The following is a description of a gene set: Genes up-regulated in the perivenous-type subclass of hepatocellular carcinomas. Sets created as part of a metaanalysis of nine public transcriptomic datasets merged into a metadataset including 1133 human hepatocellular carcinomas obtained after curative resection. For platform descriptions of each one of the 9 datasets, see Figure 1B in Désert et al., Hepatology (2017), 66: 1502-1518. species: Homo sapiens Hepatocellular carcinomas (HCCs) exhibit a diversity of molecular phenotypes, raising major challenges in clinical management. HCCs detected by surveillance programs at an early stage are candidates for potentially curative therapies (local ablation, resection or transplantation). In the long term, transplantation provides the lowest recurrence rates. Treatment allocation is based on tumor number, size, vascular invasion, performance status, functional liver reserve and on the prediction of early (< 2 years) recurrence, which reflects the intrinsic aggressiveness of the tumor. Well-differentiated, potentially low-aggressiveness tumors form the heterogeneous molecular class of non-proliferative HCCs, characterized by an approximate 50% beta-catenin (CTNNB1) mutation rate. To define the clinical, pathological, molecular features and the outcome of non-proliferative HCCs, we constructed an 1133-HCC transcriptomic metadata set and validated findings in a publically available 210-HCC RNAseq set. We show that non-proliferative HCCs preserve the zonation program that distributes metabolic functions along the porto-central axis in normal liver. More precisely, we identified two well-differentiated, non-proliferation subclasses, namely Periportal-type (wild-type CTNNB1) and Perivenous-type (mutant CTNNB1), which expressed negatively correlated gene networks. The new Periportal-type subclass represented 29% of all HCCs; expressed an HNF4A-driven gene network, which was down-regulated in mouse Hnf4a-KO mice; were early-stage tumors by BCLC, CLIP and TNM staging systems; had no macrovascular invasion and showed the lowest metastasis-specific gene expression levels and TP53 mutation rates. Also, we identified an 8-gene Periportal-type HCC signature, which was independently associated with the highest 2-year recurrence-free survival by multivariate analyses in two independent cohorts of 247 and 210 patients. Conclusion: Well-differentiated HCCs display mutually exclusive periportal or perivenous zonation programs. Among all HCCs, Periportal-type tumors have the lowest intrinsic potential for early recurrence after curative resection. from publication Désert R, Rohart F, Canal F, Sicard M, Desille M, Renaud S, Turlin B, Bellaud P, Perret C, Clément B, Lê Cao KA, Musso O (PMID 28498607) Human Gene Set: DESERT_PERIVENOUS_HEPATOCELLULAR_CARCINOMA_SUBCLASS_UP, and this is the list of marker genes: CYB5B, FAT1, SLC7A6, PARN, PLPP1, ARHGAP12, TBCE, PARVB, THAP11, KIZ, WDR12, LAMA3, RIOK2, CHKA, NMT1, CD36, SDAD1, GLUL, TTC1, SLC17A2, MRPL24, MCUR1, SEC14L2, SMYD2, RAB11FIP2, MTHFD1, MTTP, TNFAIP3, MRPS18B, PPP1R2, SAMM50, DUT, TERF2, OSER1, IARS2, PDHX, CTR9, SCD, FMO3, TGIF1, ANKRA2, KLHL21, LECT2, UTP25, TCEAL1, SPON2, PLPPR1, HPD, AQP9, RHEB, RAB4A, ASAP2, CILK1, YAP1, PREB, NAGPA, SPCS1, LEF1, AOX1, HS1BP3, HPR, GTF2IRD1, EIF2D, MRPS27 (NCBI Gene Id 64948), SLCO1B3, SLC4A4, DSP, DCXR, APOC4, ABLIM1, LGALS8, METTL25B, GNPAT, SLC30A10, CUL1, NARS2, REG3A, CYP3A4, ROCK2, HEXA, THADA, BPNT2, LGR5 (leucine rich repeat containing G protein-coupled receptor 5), PTPRG (protein tyrosine phosphatase receptor type G), CYP1A2, ACADSB, CYP1A1, RCBTB1, AP3S1, PFDN6, BCAP31, PEX19, ADH6, KATNB1, SYF2, CTNNAL1, CAP2, HSD11B1, STAM2, MID1, GGH, RB1CC1, NEDD4, NUP133, TLE1, MTR, MTIF2, AASS, CERS2, CPN2, PRKCA, ZNF189, MRPS33, MAT1A, RAD50, STXBP6, ACAA1, PMVK, HGD, PIR, CADM1, GRHPR (NCBI Gene Id 9380), RPS6KC1, CDK5, ATOX1, SYNGR1, CYP2E1, AP2B1, RNPEP, GABARAPL1, ACSM5, TIMM17A, CGREF1, SMAD3, TMCC1, APCS, NCOA2, EFR3A, ZNF200, GNAI1, NBAS, SULT2A1, DNAJC12 (NCBI Gene Id 56521), ALDH1L1, ABCC6, PBXIP1, TMEM230, LCN2, PGC, OAT, MTMR11, GREB1, AIMP1, EIF2B4, ZBTB18